Given this list of marker genes ADRA2C (NCBI Gene Id 152), GABBR1, CRH, ADRA2A, ADRA2B, here is a description of the gene set: Human Gene Set: GOBP_NEGATIVE_REGULATION_OF_EPINEPHRINE_SECRETION studied in species Homo sapiens Any process that stops, prevents, or reduces the frequency, rate or extent of the regulated release of epinephrine.